The following is a description of a gene set: Human Gene Set: GOBP_GALACTOSE_TRANSMEMBRANE_TRANSPORT species: Homo sapiens The process in which galactose is transported across a lipid bilayer, from one side of a membrane to the other. D-galactose is widely distributed in combined form in plants, animals and microorganisms as a constituent of oligo- and polysaccharides; it also occurs in galactolipids and as its glucoside in lactose and melibiose., and this is the list of marker genes: SLC2A2, SLC5A1, SLC45A1, SLC2A3, SLC2A10